The following is a description of a gene set: Three innate (B1-B, NKT, CD8aaT cells) and adaptive (B2-B, CD4T, CD8abT cells) cell-types were sorted by FACS. Three biological replicates for NKT, CD4T, CD8aaT, CD8abT cells and two biological replicates for B1 and B2 cells were generated and the expression profiles were determined using Affymetrix Mu74Av2 chip. Comparisons between the sample groups allow the identification of genes differentially expressed between the innate and adaptive cell-types. studied in species Homo sapiens Human Gene Set: GSE3039_ALPHAALPHA_CD8_TCELL_VS_B2_BCELL_DN from publication Yamagata T, Benoist C, Mathis D (PMID 16623764) Genes down-regulated in CD8A T cells versus B2 B lymphocytes., and this is the list of marker genes: LPIN2, TIPARP, ELP3, TRIP6, STX1A, HAUS1, WDR74, RNF180, ECHDC3, ETS2, EFNA5, DBP, TMEFF1, TMEM9, NPHP1, TPI1, VSIG4, BEX3, GPR34, TMCC3, MLKL, SMYD2, TIMP2, GLMP, CSRP2, CLDN4, GSTM3, IL1B, LIF, CEP152, MAFF, MEX3D, MEAK7, GSTM1, IRAK2, INTS2, LUM, PCOLCE, GDPD1 (NCBI Gene Id 359824), MEF2A, CD68, AKR1B15, BASP1, C1QC, LHFPL2, MND1, IFRD1, LTC4S (NCBI Gene Id 4056), CTSK, ESR1, SKIL, PNKD, ALKBH7, HSD3B7, IDI1, TOMM20, PIK3AP1 (NCBI Gene Id 118788), SLC7A5, MRPL3, CXCL11, EXT1, PSME1, HLA-B, FBLIM1, CHRNB1, ATP6V0D2, R3HCC1, PSMD14, C1QB, DIPK2A, TLR2, FSTL1, ARID5B, SULF1, PDGFA, ESD, LRRC41, KCNA3, PLEKHA3, IFT81, CLPP, HPGDS, TAMM41, RPS19BP1 (ribosomal protein S19 binding protein 1), WDR36, FARP1, DDT, FGFBP1, GCHFR, HSPA14, ALKBH8, LYVE1, TRAPPC6A (NCBI Gene Id 79090), KANK2, MMD, XYLT2, IFT22, TIMP1, PGK1, IFIT3, SBF2, SPART, LZTS2, CRTAP, THAP12, HERC6, SOWAHB, H1-0, NRIP1, BLOC1S5, FNIP2, GPR137B, MRPL27, CREB5 (cAMP responsive element binding protein 5), CAMK1, ABL2, F3, LDHA, RSAD1, MSH2, TANC2, RAB13, TP53I11, PRSS8, FADS2, C1orf198, ASH2L, KRT7, DPH6, CUL7, SPHK1, HEXB, WWC1, HAL, CAVIN3 (NCBI Gene Id 8990), PSMC3, VKORC1, NSMF, MZT2B, GOSR1, SLC30A9, ZFAND2A, ENO2, DUSP6, LRRC59, SLC7A2, RAB11FIP5, COLEC12, NBR1, BTBD19, TBC1D19, UBL4A (NCBI Gene Id 8266), MAPK1IP1L, THOC6, CALU, NBAS, MPG, HS2ST1, SERPINB8, NIF3L1, ZFPM1, TLCD2, TASP1, SLAMF8, ECHS1, MAGI1, MGARP, NAGLU, UAP1L1, TMED1, ERP44, CLDN2, RNASE4, GLA, ZMIZ1, ZBP1, CCL4, APOC2, SRSF2, MAN1A2 (mannosidase alpha class 1A member 2), CCRL2, SQLE, MRPL17, SRPRA, PEX11A, AGO2, NINJ1, CXCL16, IFNAR1, TYMS, AIMP2, GINS1, PHLPP1, RCL1, UACA, BCL2L11, SMOX, RBPJ, SPIRE1, BAIAP2